The following is a description of a gene set: Mouse Gene Set: MIR_7047_3P from publication Chen Y, Wang X (PMID 31504780) Genes predicted to be targets of miRBase v22 microRNA mmu_miR_7047_3p in miRDB v6.0 with MirTarget v4 prediction scores > 80 (high confidence targets). studied in species Mus musculus, and this is the list of marker genes: Fam120a, Iqce (IQ motif containing E), Ppp2r2c, Mief1, Dytn, Tmem161b, Cc2d1b, Zfp764 (NCBI Gene Id 233893), Mtpn, Ccdc70, Dclk1, Ccdc116 (NCBI Gene Id 76872), Gemin5, Map3k9 (mitogen-activated protein kinase kinase kinase 9), Septin3, Eeig2, Slc26a5, Samd4b, Eya1, Tmem170b, Ahsa1, Tfap2d, Plxna2, Mapt, Cox14, Ifnar1, Bcl6b, Tesmin, Pamr1, Rc3h2, P3h1, Syt12, Zfp764l1 (zinc finger protein 764 like 1), Mau2 (MAU2 sister chromatid cohesion factor), Hps3, Wdtc1, Wdr26, Vhl, Tbxas1, Thbs2, Bend7, Stat5b, Gnao1, Os9, Bcl7a, Fez2